Given this list of marker genes UCP1, UCP2, UCP3, SLC25A4, SLC25A5, here is a description of the gene set: species: Homo sapiens Enables the transfer of protons from mitochondrial intermembrane space into mitochondrial matrix, dissipating the proton gradient across the mitochondrial inner membrane established by the electron transport chain during the oxidative phosphorylation (proton leak). Proton leak uncouples the processes of electron transport/proton generation and ATP synthesis. Human Gene Set: GOMF_OXIDATIVE_PHOSPHORYLATION_UNCOUPLER_ACTIVITY